The following is a description of a gene set: Mouse Gene Set: MIR_12180_3P Genes predicted to be targets of miRBase v22 microRNA mmu_miR_12180_3p in miRDB v6.0 with MirTarget v4 prediction scores > 80 (high confidence targets). species: Mus musculus from publication Chen Y, Wang X (PMID 31504780), and this is the list of marker genes: Tcstv4, Tcstv2a, Alyref2, Larp6, Chmp1a, Obox1, Neurl1b, Sidt1, Ssxb9, Nob1, Morc2a, Kat6a, Frk, Cd99l2, Sdc1, Cplx2, 2310022B05Rik, Mc1r, Arrb1 (arrestin, beta 1), Mnt, Tcstv2b, Hbp1, Miga1, Jpt1, Kcna2, Smug1, Map4k4, Avpr2, Srf, Tcstv3, Zfp488, Sh3tc2, Prkd3, Tns2, Kmt2a, Ldb1, Stard4, Ccdc9, Cdh1, Fhl3, Nherf2, Atp11a, Sypl2, Akirin1, Map3k7, Sh3bgrl2, Foxm1, Srprb, Lzts3, Tafa5, Nhlh1, Necap1, Ccm2l (NCBI Gene Id 228788), Snx5, Pym1, Rwdd2b, Rnf38, Tbc1d24, Hebp1, Crim1, F2rl2, Ezh1, AW551984, Dnajc16, Ythdf1, St8sia5 (NCBI Gene Id 225742), Efna5, Sesn1, Madd, Irf9 (interferon regulatory factor 9), H2-T5, Txnip, Ppp1r12a, H2-Q7, Stk26, Atp8a1, Tcstv2c, H2-T3, Htra3